Given this list of marker genes BAHCC1, SETD7, C2CD2, GARIN1B, ROCK2, SNTB2, ANK3, ZNF681, PREPL, STK38L, JAKMIP2, BCAT1, SLITRK4, ATG14, ATXN7L1 (NCBI Gene Id 57485), PPARGC1B, MICAL2, SEMA3A, PDE1A, PGAM1, ESRRA, LONRF1, KCTD10, VAMP2, BTAF1, NR3C2, UBE3C, ZSWIM4, PTPRT, MFHAS1, GNG7, VPS37C, PRLR, KDM7A (lysine demethylase 7A), FOXO1, TRAPPC8, DAG1, MTMR2, CTTNBP2 (NCBI Gene Id 85447), UNC13A (unc-13 homolog A), MOB1B, GSK3B, GULP1, KLF4, SETBP1, TCF7L2 (transcription factor 7 like 2), GK5, SLC24A2, SSR2, NBEA, CPLX1, G3BP1, HMGXB3, KIF3B, PDS5B, HECTD2, GRIA4, SERTAD2, PELI2, KCNN3, SLC26A4 (solute carrier family 26 member 4), HNRNPR (NCBI Gene Id 10236), TOPORS, ADO, ACTR3B, MB21D2, NCOA2, RIC1, BMPER, ADAR, USP15, ARHGEF4, NAMPT, BSN, ENTPD7, WNT3, SNX16, DDX3Y, TNPO1, DEPDC1, CDYL2, UGT2B4, ZBTB46, ZNF131, TRPC1, ERBB4, CEP85L, ZNF302, TSTD2, INTS2, PPP6R3, CADM3, TAF4, COL4A3, AEBP2, GRID2, SRSF3, PSIP1, CSPP1, PKIG, ENPP3, CNIH4, CAP2, SEC14L1, DCUN1D4, RNF138, ARHGAP11A, SYT3 (NCBI Gene Id 84258), SAMD8, MAN1A1, ELOVL6, SLC16A6, ELK1, SLC10A7, ARHGAP6, RALBP1, WAPL, NUDT5, LYPLA1, BCL11A, BACH1, RALGAPB, KIAA1549, CCSAP, CREBZF, COL5A1, ELK3, UIMC1, FBXO28, DDX3X, SHISA6, VLDLR (NCBI Gene Id 7436), CCDC170, TMEM97, LATS2, HPS5, SSR1, BRWD1, ATP2B4, KRAS, BMAL1, ENTPD4, C1orf198, ZRANB1, USP42, MEF2C, MTSS1, ILDR2, WWC2, PIGH, GCNT2, KCNQ5, ROBO1, CHD1, ZBTB34, CAAP1, C6orf120, FRMPD4, MBTD1, RUNX2, ZRANB2, EFNB2, RPS6KB1, MAPRE2, SV2C, TGM2, SMIM13, SMAD5, DEPTOR, ZCCHC24 (NCBI Gene Id 219654), KCNS3, SYT2 (NCBI Gene Id 6858), PTPRD, ANKRD55, RASAL2, CSNK1G2, THRB, KCNAB3, PIK3R2, CNTNAP1, VCAN, NET1, MAPKBP1, LMTK2, PRKD3, MRAS, CRAMP1, RGL1, CLVS2, KCNB1, ASB13, ZBTB44, AVPR1A, TWSG1, PDCL (phosducin like), RNF43, STK35, PCYT1B, MRPS12, EDNRA, UGT2B10, HOXA10, ATP8A1, LMCD1, ATP1B1, ARHGAP19, SPRED1, HMBOX1, TMEM168, NUFIP2, SIAH1, DDX60L, GRIA3, C18orf54, CACNA1E, CPD, PIM2, ACSL5, KIAA1143, EYA1, TCF19, BZW2, ST6GAL2, ORC5, ZNF670, ZNF518A, SLC9A9, HIF1AN, SIRT1, JAK2, RBAK, ZCCHC14, ANGPT2, NTNG1, NCLN, MTMR12, FAM120B, STAU2, SLC25A5, PGGT1B, KALRN, LZTS1, GCLM, GAS7, PHLDB2, MED13, CHMP4B, TBC1D4, MYPOP, KCND1, STRBP, SLC30A4, SCN2A, PSD3, NADK2, PRUNE2, ROCK1, PPM1E, ZNF143, FOXN3 (NCBI Gene Id 654111), IL31RA, EBF1, MRPL16, HERC3, FCHO2, ACVR1B, MAPK10, KCNJ6, FOXN2, MEAK7, AGPS, B3GLCT, DIP2C, APC, BCAP29, RAPGEF6, SHISA7, DNAJC9, GRIK3, UTRN, YWHAG, TSEN54, OSBPL8, NEFM, ZFP1, SV2B, SPATA2, SAMD9L, PEX7, CACNA1D, CPLX2, ANXA7, MXRA5, NDRG4, WASHC4, ILRUN, ZNF652, ZNF385B, CD47 (NCBI Gene Id 961), TMPO, IGF2BP2, SDCBP, here is a description of the gene set: Genes predicted to be targets of miRBase v22 microRNA hsa-miR-135b-5p in miRDB v6.0 with MirTarget v4 prediction scores > 80 (high confidence targets). species: Homo sapiens from publication Chen Y, Wang X (PMID 31504780) Human Gene Set: MIR135B_5P